Given this list of marker genes ANO1, SLC5A8, SLC5A5, MFSD8, SLC26A4, SLC5A6, here is a description of the gene set: Enables the transfer of iodide ions from one side of a membrane to the other. Human Gene Set: GOMF_IODIDE_TRANSMEMBRANE_TRANSPORTER_ACTIVITY studied in species Homo sapiens